Given this list of marker genes HELLPAR, ATP8B1, FDXR, CFI, CORIN (corin, serine peptidase), MYT1L, CD46, ASH1L, ABCB4, F5, PPARG, HBA1, DHPS, SLC25A20, CYP11B1, STOX1, NR3C2, CFH, LBR, LMNA, NR1H4, HBA2, NOS3, EP300, ABCB11, SPTBN1, CYP11B2 (cytochrome P450 family 11 subfamily B member 2), ADGRG6, here is a description of the gene set: Human Gene Set: HP_TOXEMIA_OF_PREGNANCY Pregnancy-induced toxic reactions of the mother that can be as harmless as slight Maternal hypertension or as life threatening as Eclampsia. studied in species Homo sapiens Toxemia of pregnancy